The following is a description of a gene set: studied in species Mus musculus Mouse Gene Set: REACTOME_ERBB2_ACTIVATES_PTK6_SIGNALING ERBB2 Activates PTK6 Signaling, and this is the list of marker genes: Nrg3, Ereg, Btc, Erbb2, Hbegf, Nrg1 (neuregulin 1), Egf, Erbb3, Ptk6, Egfr, Erbb4